Given this list of marker genes TBC1D20, STAU1, DDB1, STAT1, IFIT1, HACD3, DYNLT1, VAPB, here is a description of the gene set: species: Homo sapiens Human Gene Set: GOBP_REGULATION_BY_VIRUS_OF_VIRAL_PROTEIN_LEVELS_IN_HOST_CELL Any virus-mediated process that modulates the levels of viral proteins in a cell.